The following is a description of a gene set: studied in species Homo sapiens Raynaud phenomenon Human Gene Set: HP_RAYNAUD_PHENOMENON, and this is the list of marker genes: RNASEH2B, MECP2, GUCY1A1, IGHG1, SEC61A1, LSM11, BANK1, PDCD1, ADAR, SPP1, TLR7, LMNA, AGXT, SAMHD1, UBE2L3 (NCBI Gene Id 7332), PTPN22, COL4A1, RNASEH2C, CLCNKB, IRF5, TNIP1, ZMPSTE24, STING1, HLA-DRB1, RNASEH2A, FCGR2B, DNASE1, PXK, RNU7-1, ADA2, HRAS, JAZF1, ETS1, FCGR3B, APOLD1, ITGAM, IFIH1, C4A, IL10, TREX1 (three prime repair exonuclease 1), TNFSF4, RNF125, IRAK1, LBR, BLK, ACP5, C4B, KIAA0319L, TNFAIP3, COQ2, CTLA4, CR2, SLC12A3, SAT1, STAT4